Given this list of marker genes PTHLH, LAMB3, UPP1, GJB5, SERPINB5, FGFBP1, S100A14, KRT19, AHNAK2, LAMA3 (NCBI Gene Id 3909), ANXA3, TP63 (tumor protein p63), ANXA8, CLCA2, COL17A1, F3 (coagulation factor III), GPR87, ALDH1A3, CDH3, S100A2, SFN, LAMC2, AREG, AMIGO2, KRT17, GJB3, FERMT1, here is a description of the gene set: Neighborhood of CDH3 cadherin 3, type 1, P-cadherin (placental) in the GNF2 expression compendium studied in species Homo sapiens Neighborhood of CDH3 Human Gene Set: GNF2_CDH3